The following is a description of a gene set: Human Gene Set: GOBP_NUCLEUS_ORGANIZATION species: Homo sapiens A process that is carried out at the cellular level which results in the assembly, arrangement of constituent parts, or disassembly of the nucleus., and this is the list of marker genes: LMNA, NECTIN2, USP50, RNF8, H3-3A, HMGB2, LMNB2, CFAP43, CHEK1, UBE2I, NUP93, SMARCA5, BRDT (NCBI Gene Id 676), ETS1, DES, TNP1, TMF1, VPS4A, CHMP4B, SIRT2, BIN1, FSHR, LPIN1, BEND3 (NCBI Gene Id 57673), SUN1, NUP98 (NCBI Gene Id 51457), SPAST, WDR73, DCTN1, EMD, ACTR6, RRN3, NUP153, UBXN2A, TOR1B (NCBI Gene Id 84822), NUP35, NOLC1, TPR, DYRK3, CELF3, PRM1, PIWIL1, WBP2NL, CDK1, SYNE1, DMPK, CHMP3, CHMP2A, SUV39H1, PRKCA, VPS4B, NUP107, SIRT1, REEP3, NUP155, SYCP3, AGFG1, KAT5, BANF1, RPS19, SELENOF, DDX11, TBPL1, GOLM1, PAFAH1B1, PHF2, TOR1AIP1, ARMC2, RTN4, AKAP8L, WEE2, SUMO1P1, REEP4, PLEC, EPC1, TMEM201, TNP2, HIPK2, TSSK6, SYCP1, NDC1, BROX, CTDNEP1, ZPR1, BAZ2A, SERBP1, TMEM43, TMEM170A, CHD5, NUP205, AHCTF1, NSFL1C, SEH1L, NEK6, WRAP53, GPER1, CHMP2B, IRAG2, H3-3B (NCBI Gene Id 3021, H3.3 histone B), AFF2, PML, EMG1, CCER1, CHMP4A, ZMPSTE24, DMRTC2, UBXN2B, PHF8, POLR1B, CHMP5, LMNB1, CHMP1A, MFSD14A, NEAT1, ATR, H2BC1, PYGO2, H1-7, NUMA1, AGFG2, PITPNB, CEP55, PLK1, RRP8, CHMP1B, KDM3A, PDCD6IP, FXR1, CCDC146, PRKCB, TARDBP, PYGO1, SRPK1, VRK1, CFAP44, NUP54, NUP133, CHMP6, NEMP1, LEMD2, CHMP4BP1, PARP11, HABP4, SRPK2, ATXN7, SUN2, USPL1, PRM2, SUMO1, CDKN2A, CHMP4C, NFE2L1 (NCBI Gene Id 6937), CHMP7 (NCBI Gene Id 91782), PSME4, ANKLE2, RCC1, MACROH2A1, TOR1A, USP36